Given this list of marker genes TEFM, HSP90B1, MTMR2, MRPS12, MEG3, CHST11, SEPHS2, GSS, BMI1, PARD3B, EMD, FABP4, TMEM120B, MAK16, PWP1, ANXA1, STK40, AMPD2, GRK2, NGEF, MSN, FAM162A, IRF4, NUP50, OTOG, GRAP2, FUBP1, DNAJC3, TIMM23, NCKAP1, LIN28A, SDCBP2, UQCR11, RBM8A, ARPC3, CEP19, TMEM222, H2AJ, PPP3CC, PADI1, ATP5PF, TRAPPC1, ST7, GRAMD1A, CCT6A (NCBI Gene Id 908), FKBP4, NPPC, CCL7, SNRPD1, CHI3L1, NOL11, RBM18, ELP5, MLLT11, ARHGAP35, NMNAT1, KYAT3, S100A11, TP53BP1, YIPF5, KPNA3, STK4, SIKE1, SNRPD2, STT3A, MYOZ1, GPN2, VAV3 (NCBI Gene Id 10451), KPNA1, MSANTD4, LMO4, SCX, PSEN1, CD80, BNIP1, TBXA2R, FCGR2A, COQ3, TSHZ1, KIAA0319L, HRAS, ACAD9, ADA, BCKDHB, RAB11A, EMC2, RND3, RNF5, HMGCS1, ATXN7L3, RFFL, ITGAL, POLR3D, OSBPL2, SUCO, DGAT2, CFL2 (NCBI Gene Id 1073), STMP1, LTN1, NOTUM, IL36G, KIF3C, NSMF, CSDE1, TRPC4AP, TNNT2, CPEB2, PNO1, ELOC, PSMD4, ABHD14A, SEC23B, NCBP1, BTBD1, ZDHHC12, RABGEF1, ATG4D, HOXC13, CELA1, SYS1, CDKN2B, SYNE1, MAGT1, GFER, PDZD11, FCGR3A, IDNK, CDK8, IMPACT, HRK, POLR2K, PSMD10, RAC2, HMOX1, MED8, EPHA4, LSM4, ZWINT, CUL1, WDR75, DDX54, PABIR1 (NCBI Gene Id 116224), ATP13A3, CAVIN4, THUMPD3, SLC41A2, EIF3I, TRIM21, SKP1, GSR, PDIA6, SOD2, APPBP2, CAMSAP1, CCL24, EHBP1L1, ACTR1B, MAGOHB, DUSP2, DCAF1, DDX24, UXT, SERPINE2, PLAGL2, DDX21, AKT2, ARL2BP, EIF6 (NCBI Gene Id 3692), PSMD12, CYTH3, SYNE4, CD2BP2, DDX10, GNL3, COL5A1, BOLA1, CACNG2, ABCC1, ZNF703, SLC6A17, IGFBP4, NFAT5, UBL5, NCOA5, PPP1R11 (NCBI Gene Id 9160), KRT5, TUBGCP5, CHAC2, PGRMC2, ITGAV, TFPI, SLC4A2, GPR155, ELAC2, AZIN1, DRG2, ACSL5 (acyl-CoA synthetase long chain family member 5), SF3A3, FCER1G, MRPL13, here is a description of the gene set: Genes up-regulated in comparison of dendritic cells (DC) stimulated with LPS (TLR4 agonist) at 8 h versus DC cells stimulated with poly(I:C) (TLR3 agonist) at 8 h. Human Gene Set: GSE17721_LPS_VS_POLYIC_8H_BMDC_UP mouse primary BMDCs were stimulated with tlr ligands and gene expression changes were profiled on Affymetrix arrays from publication Amit I, Garber M, Chevrier N, Leite AP, Donner Y, Eisenhaure T, Guttman M, Grenier JK, Li W, Zuk O, Schubert LA, Birditt B, Shay T, Goren A, Zhang X, Smith Z, Deering R, McDonald RC, Cabili M, Bernstein BE, Rinn JL, Meissner A, Root DE, Hacohen N, Regev A (PMID 19729616) studied in species Homo sapiens